The following is a description of a gene set: Viral RNP is assembled in the host cell nucleus through the interaction of full-length negative strand viral RNA (vRNA) and the viral nucleocapsid (NP) and matrix (M1) proteins. Studies of interactions of the purified components in vitro and of tissue culture model systems expressing various combinations of the components have established roles for both NP and M1 proteins in the assembly of a complex that has the physical properties of vRNP purified from virions and that can be exported from the host cell nucleus. Viral RNP complexes have been found in the nucleoplasm, and also in the nuclear periphery, associated with the nuclear matrix or chromatin, particularly for vRNA-containing complexes and M1 protein. studied in species Homo sapiens Reactome Pathway: Viral RNP Complexes in the Host Cell Nucleus part of: Export of Viral Ribonucleoproteins from Nucleus, and this is the list of marker genes: NP, HSPA1A, PB1, PA, PB2, M, NS